Given this list of marker genes Igf2r, Rab18, Golph3, Tpd52l1, Dsg2, Wsb2, Dusp6, Timd2, Serp1, Bag2, Cmas, Fhdc1, Cradd, Itpr2, Perp, Mydgf, Lxn, Cd9, Ndst1, Pdia4, Atp6v1a, Dap, here is a description of the gene set: from publication Landis MD, Seachrist DD, Montañez-Wiscovich ME, Danielpour D, Keri RA (PMID 15897883) Mouse Gene Set: LANDIS_ERBB2_BREAST_TUMORS_65_UP Upregulation of HER2/ErbB2/Neu occurs in 15-30% of human breast cancers and correlates with poor prognosis. Identification of ErbB2/Neu transcriptional targets should facilitate development of novel therapeutic approaches. Development of breast cancer is a multistep process; thus, to identify the transcriptomes associated with different stages of progression of tumorigenesis, we compared expression profiles of mammary tumors and preneoplastic mammary tissue from MMTV-Neu transgenic mice to expression profiles of wild-type mammary glands using Affymetrix microarrays. We identified 324 candidate genes that were unique to ErbB2/Neu-induced tumors relative to normal mammary gland tissue from wild-type controls. Expression of a subset of these genes (82) was also changed in the preneoplastic mammary glands compared to wild-type controls, indicating that they may play a pivotal role during early events of ErbB2/Neu-initiated mammary tumorigenesis. Further analysis of the microarray data revealed that expression of several known transforming growth factor (TGF)-beta target genes was altered, suggesting that the TGF-beta signaling cascade is downregulated in ErbB2/Neu-induced tumors. Western blot analysis for TGF-beta-Receptor-I/ALK5 and immunohistochemistry for TGF-beta-Receptor-I/ALK5 and phosphorylated/activated Smad2 confirmed that the Smad-dependent TGF-beta signaling cascade was inactive in these tumors. Although absent in most of the tumor, phosphorylated Smad2 was present in the periphery of tumors. Interestingly, presence of phosphorylated/activated Smad2 correlated with expression of Activin-Receptor-IB/ALK4, suggesting that although Smad-dependent TGF-beta signaling is absent in ErbB2/Neu-induced tumors, Activin signaling may be active at the leading edge of these tumors. Cumulatively, these data indicate that the TGF-beta pathway is intrinsically suppressed in ErbB2/Neu tumors via a mechanism involving loss of TGF-beta-Receptor-I/ALK5. Up-regulated genes from the 65 most significantly changed (p<0.01) genes identified by two analytical methods in the mammary tumors induced by transgenic expression of ERBB2. studied in species Mus musculus